The following is a description of a gene set: Mouse Gene Set: GOBP_LNCRNA_TRANSCRIPTION species: Mus musculus The transcription of lncRNAs, non-coding RNAs over 200 nucleotides in length, from a DNA template., and this is the list of marker genes: Zc3h4, Nfatc2, Wdr82, Topaz1, Iqch, Celf3